The following is a description of a gene set: studied in species Mus musculus Mouse Gene Set: chr12A3, and this is the list of marker genes: Gm29007, Gm24986, Agmo, Gm19056, Gm10933, Gm34809 (NCBI Gene Id 102638187), Cdhr3, Gm18622, Bzw2, Gm40392, D630036H23Rik, Atxn7l1, Gm7252, Gm34408, Gm4257, Tspan13, Gm18338, Gm18442, Gm40394, Gm34662, Prkar2b, Nampt, F730043M19Rik, Gm33308, Gm9368, Atxn7l1os2, 4921508M14Rik (RIKEN cDNA 4921508M14 gene), Gm18029, Gm18115, Prps1l1, Gm9370, Etv1 (NCBI Gene Id 14009), 9130015A21Rik, Snx13, Gm25913, Gm18025, Pik3cg, Lrrc72, Gm33111, Agr3, Gm40375, Gm34047, Gm19046, 4930428E07Rik, 4933406C10Rik, Gm25438, Sypl1, Twist1, Gm18026, Meox2, Dgkb, Mir680-3, Gm35755, Gpr22, Atxn7l1os1, Mir5099, Gm34611 (NCBI Gene Id 102637919), Gm34215, Sostdc1, Hbp1, Gm40383, Polr1f, Ube2frt, Hdac9, Gm46317, Gm19563, Agr2, Ccdc71l, Gm24922 (predicted gene, 24922, NCBI Gene Id 115488079), Gm9472, Gm17820, Ferd3l, Gm24429, Crppa, Gm7002, Gm18726, Efcab10, Ahr, Ankmy2